The following is a description of a gene set: Variation in DNA sequence contributes to individual differences in quantitative traits, but in humans the specific sequence variants are known for very few traits. We characterized variation in gene expression in cells from individuals belonging to three major population groups. This quantitative phenotype differs significantly between European-derived and Asian-derived populations for 1,097 of genes tested. For the phenotypes with the strongest evidence of cis determinants, most of the variation is due to allele frequency differences at cis-linked regulators. The results show that specific genetic variation among populations contributes appreciably to differences in gene expression phenotypes. Populations differ in prevalence of many complex genetic diseases, such as diabetes and cardiovascular disease. As some of these are probably influenced by the level of gene expression, our results suggest that allele frequency differences at regulatory polymorphisms also account for some population differences in prevalence of complex diseases. Human Gene Set: SPIELMAN_LYMPHOBLAST_EUROPEAN_VS_ASIAN_2FC_UP from publication Spielman RS, Bastone LA, Burdick JT, Morley M, Ewens WJ, Cheung VG (PMID 17206142) Genes up-regulated more than two-fold in lymphoblastoid cell lines from European population compared to those from Asian population. species: Homo sapiens, and this is the list of marker genes: ATP8B1, COPG1, RGS20, ROBO1 (roundabout guidance receptor 1), FCER2, ARPC4, DPYSL2 (NCBI Gene Id 1808), RRP1, TCF7, HSPB1, UGT2B17 (NCBI Gene Id 7367), STXBP2, MEIS2